Given this list of marker genes PMS1, FMR1, VCP, PMS2, TREX1, SLC19A3, CTNNB1, COL4A3, AVPR2, AMPD2, HLA-B, PERCC1, GCSH, CDKN2A, GRIA4, PTH, ALDH7A1, SLC39A4, MOCS2, TRMT5, ASS1, IFNGR1, ABCC6, EXOC8 (exocyst complex component 8), IL10, PAX2, MLH1, FGF8, NPHS1 (NCBI Gene Id 8183), CUX2, TBC1D8B (TBC1 domain family member 8B), UFC1, SLC6A3, ADAR, NDUFA6, RNASEH2C, SMARCB1, SMC1A, RNU4-2, HTT, PYGL, MT-ATP6, COG4, HTRA1, SMPD1, FOXH1, NRCAM (neuronal cell adhesion molecule), EHMT1, MSH2, PAH, NUP205, NUP133, PRF1, ABCC8, STIL (STIL centriolar assembly protein), POGZ, TLR4 (NCBI Gene Id 7099), PLCE1, PHOX2B, GLRX5, DAAM2, ASAH1, PI4K2A, NUP107, STX16, DNM1, TP53, DARS1, NAXD, PSEN1, STUB1, GAS1, CDON, SDHB, OSTM1, EMP2, GCDH, TGIF1, CAMK2B, CHMP2B, MAGI2, SDHAF1, CRB2, NPHS2, HSPG2, AQP2, RNU7-1 (NCBI Gene Id 100147744), DLL1, PRNP, DNMT1 (NCBI Gene Id 1786), SLC1A2, SQSTM1, ATP5F1A, NUP93, TRPC6, TTI2, DDC (dopa decarboxylase), SLC2A3, GNAS, COQ8B, EPCAM, PRRT2, IL23R, GCH1, SEMA4A, ASH1L, VPS50, ZIC2, CPS1, GBA1, ACTN4, CRIPTO, NDUFAF4, RNASEH2A, BRCA2, IL12A-AS1, FGFR1, FBP1, AVP, ASNS, STAT4, NODAL, CCR1, LIN28B, INF2, SUCLA2, RPS20 (ribosomal protein S20), SEPSECS, ANKFY1, SLC39A14, KLRC4, MUTYH, TK2, IFIH1 (interferon induced with helicase C domain 1), NSDHL, TSEN15, DPYD, SLC25A19, GAPVD1, TRANK1, PTCH1, FIG4, SLC25A1, RNF13, VPS53 (NCBI Gene Id 55275), HIKESHI, JPH3, NAXE, NUP37 (nucleoporin 37), ARHGAP24, GLI2, SAMHD1, PTPRO, PCBD1, PLPBP, SLC2A1, EXOSC8, PTS, KRAS, PRKAR1A, TGFBR2, TRMU, GRN, SLC1A4, PYCR2, SDHA, VPS13A, ATM, ITPA, NAA20 (NCBI Gene Id 51126), TH, ANLN, ARHGDIA, PSAP, WT1, GYS2, PHGDH, ALG9, ENPP1, NUP85, IBA57, CNP, ASPA, ARG1, ERAP1, IL12A, GLDC (NCBI Gene Id 2731), CACNA1A (calcium voltage-gated channel subunit alpha1 A), AIFM1, UBA5, ST3GAL5, TREM2, C4A, CYP2R1, NACC1, VDR, SLC46A1, FOCAD, NHLRC2, CD2AP, TMEM237, MYO1E, OTC, RNASEH2B, SDHD, ARV1, POLR1A, SIX3, HLCS, PLCH1 (NCBI Gene Id 23007), MYCN, MECP2 (methyl-CpG binding protein 2), SLC25A20, TMEM106B, PIK3CA, ALPL, LMO1, PANK2, ASL, MAPT, ALK, STAG2, SCN1A, CHD2 (chromodomain helicase DNA binding protein 2), PPT1, HIBCH, UBAC2, MTHFS, TYROBP, ST3GAL3, GALC, FOXRED1, MED12, NAA10, APOL1, TSPOAP1, GABRB3, NFIX, NDUFS1, CHEK2, HBB, MAPK10, MSH6, HACE1, CLP1, DISP1, HLA-DQB1, SHH, SPTBN1, ZNRF3, MED23, ADNP, NUP160, FOXG1 (NCBI Gene Id 2293), BMPR1A, SLC25A13, DCX, NDP, QDPR, TERT, CAMK2A, CARS1, TCN2, CYP27B1, ACOX1, CLN8, MEFV, FDFT1, YIF1B, NDUFA2, FBP2, POLD1, SLC16A2, POLE, FAS, LSM11, here is a description of the gene set: A proneness to anger, i.e., a tendency to become easily bothered or annoyed. Irritability species: Homo sapiens Human Gene Set: HP_IRRITABILITY